The following is a description of a gene set: species: Homo sapiens A specialized cell-cell junction found between the cells of the excretory system, which provides a barrier for filtration of blood or hemolymph. Human Gene Set: GOCC_FILTRATION_DIAPHRAGM, and this is the list of marker genes: NPHS1, NPHS2, MAGI2, KIRREL2, CD2AP, TRPC6, IQGAP1, PODXL